The following is a description of a gene set: Combining with an extracellular or intracellular messenger, and in cooperation with a nearby primary receptor, initiating a change in cell activity. Mouse Gene Set: GOMF_CORECEPTOR_ACTIVITY studied in species Mus musculus, and this is the list of marker genes: Cd4, Lilra6, Cxcr6, Il12rb2, Pira12, Gpr15, Lrp5, Fcrl1, Eng, Ramp2, Il18rap, Csf2rb, Acvr2a, Ackr3, Lrp1, Ngfr, Il2rg, Gfra3, Rgma, Rgmb, Kdr, Cd22, Cd80, Nradd, Lbp, Csf2rb2, Reck, Igsf1, Erbb2, Lrp6, Cripto, Il10rb, Il6st, Il17rc, Ramp3, Ramp1, Lrp4, Pira2, Cd8b1, Tgfbr3, Hjv, Il1rap, Il2rb, Gfra4, Cspg4, Pira13